Given this list of marker genes CYP11A1, REST, WNT4, AKR1C1, AKR1B1, AKR7A2, SULT1C4, CACNA1H, AKR1C3, BMP2, HSD11B2, BMP5, DKK3, AKR1B10, AKR1C4, CYP11B2, H6PD, DGKQ, AKR1C2, CYP11B1, AKR1A1, CBR4, here is a description of the gene set: The chemical reactions and pathways involving tertiary alcohol. studied in species Homo sapiens Human Gene Set: GOBP_TERTIARY_ALCOHOL_METABOLIC_PROCESS